Given this list of marker genes SPTLC2, AEBP2, PARP15, DPY19L2, NSD3, FBXO36, PPP1R21, NOSIP, SCN2B, HLCS, EIF2S1, PHF14, DDI2, ADIPOR2, SYT1, FMNL2, ZFYVE28, NOVA1, PAK1, GFM2, FOXF1, CNTNAP2, RLIG1, AKAP12, GATA6, SLC35B4, TTC3, SRFBP1, TMPRSS11D, WWOX, SPAG1, MEST, GAGE1, PTP4A2, ACSL1, GRIK5, TBX21, PTPN3, MEF2A, ALS2, KCNJ13, COL4A3, LPGAT1, AIRIM, PDE4A, CCDC59, KLHL1, GATA4, ZDHHC21, HUS1, NEK2, TPTEP2-CSNK1E, EIF4G3, ANKHD1, CAST, LINGO2, RAPGEF6, MAP4K3, RAB39A, PDE10A, B3GALT1, GABRA1 (NCBI Gene Id 2554), SEMA6D, SH3GLB1, CEP120, METTL21C, BTBD7, TLE4, DERL1 (NCBI Gene Id 79139), SPACA1, SEMA3D, RBPJ, ZNF277, DNAJC11, ASB3, SLC1A2, ANKRD13B, PALLD, PTPN1, KCNAB1, ULK2, ZBTB20 (NCBI Gene Id 26137), NUP62 (NCBI Gene Id 51551), DLG3, SLC10A7 (solute carrier family 10 member 7), NUBPL, KLHL31, FAM114A1, PAN3, GNAO1, NFAT5, UNC80 (NCBI Gene Id 84540), RD3, SLC22A5, ABHD5, DHFR, SULF1, CHML, CDC37L1, PDZD8, MINPP1, NHEJ1, KLF3, ALCAM, PAX5, C2orf88, SKP1, NR4A3, FYB2, ATP6V1G3, SCAI, CELF4, TSTD2, NPY1R, UHRF2, PLEKHA3, TSPAN2, CSNK2A1, EDIL3, TENT2, HOXB9, SRP19, TCAIM, NEMP1, DIAPH2, CRIPT, PAICS (NCBI Gene Id 647765), CEPT1, MTRF1L, EMC3, MOCS2, ODF2L, IP6K3, MB21D2, ATP10A, ZNF704, INO80D, DIPK1A, FAM98B, DNAJC24, HAPLN1, TCF12, DSPP, KANK2, MATR3, CYS1, MYL1, IRAG1, MBNL3, NBEA, GCSAM, SENP2, CACNG2, LDLRAD4, IQCH, SIRT3 (sirtuin 3), ARMC8, BBOF1, DNAL1, IFT70B, ZNF582, GABRR2, COL11A1, EXOC6B, PCP4, ANKRD40, PPP3CC, RBM27, DLG2, PDPK1, TMPRSS3, ETV1, FBXO22, LMAN2, SOS1, CDH18, SGK3, CNGB1, OTULIN, RASEF, STON2, YWHAZ, CBR4, ERCC6L2, MRPL19, RBM46, GATAD1, GAPT, BRSK2, SOX14, RETREG3, CCNJ, TTC39C, DAAM1, PIGF, OPA1, PRKCA, UBR5, ZMAT4, MBNL1, LAMP3, TNPO3, ENTPD1, VSTM2A, ZC3H10, C1orf141, CRISP3, HABP4, TMEM209, ORC4, RASSF8, ELOVL2, SFXN1, YOD1, MAT2B, NXT2, APRG1, SLC18A2, SUB1, CCDC73, BCL11B, FGF7, EEA1, ROR1, KCNA1, FOXO1, PPARGC1A, ITPRID2, ADSS2, NRXN1, C11orf71, TACC1 (transforming acidic coiled-coil containing protein 1), IP6K2, CDH20, ONECUT2, RORA, ASB8, RBM47 (NCBI Gene Id 54502), NUP155, PLCXD3, TEX55, FBXW2, BCL6, TENM1, PAX6, PPP4R3B, NOTCH2NLA, ELK4, DTD2, C8orf44-SGK3, RAB7A, PPP1R3D, STXBP3, UST, SOCS5, PRKDC, CSNK1E, here is a description of the gene set: species: Homo sapiens from publication Chen Y, Wang X (PMID 31504780) Human Gene Set: MIR4677_5P Genes predicted to be targets of miRBase v22 microRNA hsa-miR-4677-5p in miRDB v6.0 with MirTarget v4 prediction scores > 80 (high confidence targets).